Given this list of marker genes ZNRF3, TRIAP1, FLI1, CEP85L, NOP56 (NOP56 ribonucleoprotein), BRIX1, MICOS10, SCRIB, TTLL1, POLR1C, ZCCHC17, TTI2, MRPL57, RNF7, BRPF1, USP38, CETN2, COMMD3, NUDT6, RNF4, NDUFAF4, EDC3, TCFL5, ABR, KBTBD7, UTP4, TMEM87B, MRPL15, ATPSCKMT, TRMT1, RUNX1, PAQR4, RPUSD2, SUV39H2, TOMM40L, DNAJC11, DCP1B, OSGEPL1, ASB7, TMEM168, RLIG1, NME6, ST6GAL1, IRF5, ZBED5-AS1, TP53RK, WNT5B, BAHD1, ANP32A, CARD9, C9orf40, CIAPIN1, ZNF565, ARF4, THNSL1, MTFR2, FBXO21, URB2, GTF3C2, CTPS1, EXO5, SNAPC5, PIN4, SNRNP35, ZNF813, ADSL (adenylosuccinate lyase), XPA, TBL2, COPS9, FBXO33, UNG, RAD52, POLR3B, MTNAP1, MTRES1, FRMD4A, GRWD1, CFAP20, FRAT2, SMIM27, PTRH2, FLVCR2 (FLVCR choline and putative heme transporter 2), THUMPD3, PRADC1, SRSF2, TFB2M (transcription factor B2, mitochondrial), DNAAF2, POP5, ZNF35, RAB32, RANGRF, IDE, MTFMT, HYCC1, CCDC51, PDCD7, RPA1, TRAK2, HSD17B10, INIP, WRNIP1, COL15A1, ZNF319, TNRC18, ESRRA, TSHZ1, COA4, NDUFA5, TRMT12, MDM1, TLR6, SAMM50, MRM2, AKTIP, UMPS, WDR36, IKBIP, DNAL1, IL16, MAP7, NAPEPLD, POP1, ASL, ZNF443, UTP23, PDIK1L, ACTL6A, HSBP1, ISY1, ZNF544, DCTPP1, HRH1, PDHB, FOS, TRIM32, DCAF4, RPP40, TIMM21, PXMP4, PRPF31, FBXL4, COA5, ORC5, NRROS, TACO1 (NCBI Gene Id 51204), BAIAP2-DT, PIK3R4, BLOC1S4, GAR1, VASH1, ZNF561, MON1B, EEF1E1, TWF2, GBA2, ZSCAN5A, ZNF559, MRTFA, IPO11, GXYLT1, KAT14, PHF14, RCAN3, NLRP2, PPARGC1B, PPP1CC, FAHD1, CCNE1, FBXO45, RIOX1, DDIAS, SHQ1, ZNF57, PIPOX, DDX23, GLCE, HS2ST1, ZCCHC24, NUFIP2, SURF6, SSNA1, MRPL12, TCHP, FKBP14, WDR37, C16orf54 (NCBI Gene Id 728070), RNF44, SLC19A2, PCYOX1L, WDR53, RRP15, MTFR1, ZYG11B, MRPL43, GEMIN7, ZNF641, TARBP2, UTP15, LYRM7, here is a description of the gene set: The dendritic cell (DC) is a master regulator of immune responses. Pathogenic viruses subvert normal immune function in DCs through the expression of immune antagonists. Understanding how these antagonists interact with the host immune system requires knowledge of the underlying genetic regulatory network that operates during an uninhibited antiviral response. In order to isolate and identify this network, we studied DCs infected with Newcastle Disease Virus (NDV), which is able to stimulate innate immunity and DC maturation through activation of RIG-I signaling, but lacks the ability to evade the human interferon response. To analyze this experimental model, we developed a new approach integrating genome-wide expression kinetics and time-dependent promoter analysis. We found that the genetic program underlying the antiviral cell state transition during the first 18-hours post-infection could be explained by a single regulatory network. Gene expression changes were driven by a step-wise multi-factor cascading control mechanism, where the specific transcription factors controlling expression changed over time. Within this network, most individual genes are regulated by multiple factors, indicating robustness against virus-encoded immune evasion genes. In addition to effectively recapitulating current biological knowledge, we predicted, and validated experimentally, antiviral roles for several novel transcription factors. More generally, our results show how a genetic program can be temporally controlled through a single regulatory network to achieve the large-scale genetic reprogramming characteristic of cell state transitions. from publication Zaslavsky E, Hershberg U, Seto J, Pham AM, Marquez S, Duke JL, Wetmur JG, Tenoever BR, Sealfon SC, Kleinstein SH (PMID 20164420) studied in species Homo sapiens Human Gene Set: GSE18791_CTRL_VS_NEWCASTLE_VIRUS_DC_8H_UP Genes up-regulated in comparison of control conventional dendritic cells (cDC) at 0 h versus cDCs infected with Newcastle disease virus (NDV) at 8 h.